The following is a description of a gene set: species: Homo sapiens Human Gene Set: GSE41867_DAY6_VS_DAY8_LCMV_ARMSTRONG_EFFECTOR_CD8_TCELL_DN Genes down-regulated in CD8 T effector cells, acute infection with LCMV-Armstrong: day 6 versus day 8. from publication Doering TA, Crawford A, Angelosanto JM, Paley MA, Ziegler CG, Wherry EJ (PMID 23159438) During acute viral infections, naïve CD8+ T cells differentiate into effector CD8+ T cells and, after viral control, into memory CD8+ T cells. Memory CD8+ T cells are highly functional, proliferate rapidly upon reinfection and persist long-term without antigen. In contrast, during chronic infections, CD8+ T cells become “exhausted” and have poor effector function, express multiple inhibitory receptors, possess low proliferative capacity, and cannot persist without antigen. To compare the development of functional memory T cells with poorly functional exhausted T cells, we generated longitudinal transcriptional profiles for each., and this is the list of marker genes: TRMT112 (NCBI Gene Id 51504), UTP3, MED29, TFPT, GYPC, FTO, POLR1G, VCPKMT, NUP188, SCOC, MCM2, EXOSC5, YWHAG, CTH, ALDH18A1, POP7, MRPL52, SNRPD3, MDN1, CHAMP1, MRPL17 (mitochondrial ribosomal protein L17), MRPL22, CRELD1, IFRD1, TNFSF11, MPHOSPH6, MRPS18B, COA7, SP7, CEP63, JMJD4, UBOX5, RPAP1, TRAF6, SLC25A38, MTFR1, HSPA8, NDUFB9, MANF, AEN, RBM34, IPO5, SRP54, MRPS26 (mitochondrial ribosomal protein S26), SLC25A39, HNRNPM, MRPL13, SNHG32, GTF2F2, FAAP24, BZW2, HSPA5 (heat shock protein family A (Hsp70) member 5), MFHAS1 (NCBI Gene Id 9258), WDR73, POLR2E, DDX39B, FASTKD2, DPH6, EIF5 (NCBI Gene Id 1983), PPRC1, DYNLRB1, PAK1IP1, VMA21, LIPT2, SEH1L, SOD1, ALDH9A1, TOMM22, DNPH1, CDK4, ZNG1B, HNRNPLL, METAP2, RAD23A, RWDD1, USP10, DUS1L, SWAP70, PPIE, YWHAB, MSRA, TEDC2, BLOC1S4, PHF5A, CCT5, TMEM14C, COPS6 (COP9 signalosome subunit 6), NME1, ALG11, PAICS, PNO1, NCOA5, LSM7, COPB2, TTC4, UBE3D, TBC1D10A (TBC1 domain family member 10A), DNAJC2, MCM3, ORMDL2, ZPR1, TMEM69, FASN, AAAS, TADA2A, TIMELESS, CAND1, EEFSEC (NCBI Gene Id 96019), SRP19, MTM1, AIMP2, PEX12, EEF1G, GET3, LZIC, ACTR10, UBXN8, ELOVL6, ACOT7, PIGY, NUDT2, ELOC, TRIM44, GPS1, AHCY, PSMD13, MED30, GSTZ1, DDX49, SRPK1, DNAJB11, TPRKB, TRMU, RBMXL1, NOB1, MSRB2, NDUFA4, COPS7A, BTBD19, WDR83OS, DCP1A, DDX39A, TMEM209, NUTF2, TIMM22, UBAP2, LARS2 (NCBI Gene Id 23395), REXO4, HARS1, DDX10, NOC2L, UBE2I, N6AMT1, USP31, TNFSF9, LYPLA2, NSFL1C, C19orf53, TMEM177, SNHG7, USP5, SPRYD4, C1orf50, UTP15, FUBP3, PCBD2 (NCBI Gene Id 84105), SUPT3H, GRPEL1, SF3B5, DPH5, BCL2A1, BHLHE40, NUDC, IBA57, EIF6, RCE1, RPA2, AFG2B, CENPU, FAM118B, TXNDC9, TIMM8B, SPAG7, MRPL1, MTG2, NDUFS7, SRRM1, SYCE2, NOC3L, NLE1, SLC35B1, ZNF213, MTRR, NEDD8, HAGH, POP1, TNFAIP1, KGD4, WDR74, CLDN7